The following is a description of a gene set: Human Gene Set: KEGG_MEDICUS_REFERENCE_MLK_JNK_SIGNALING_PATHWAY species: Homo sapiens Pathway Definition from KEGG: MLK -> MKK4/7 -> JNK MLK-JNK signaling pathway. Pathway ID: N01594. Pathway type: Reference. Pathway class: nt06526 MAPK signaling., and this is the list of marker genes: MAPK9, MAP3K10, MAP3K13, MAPK8, MAP2K7, MAPK10, MAP3K11, MAP2K4, MAP3K12, MAP3K21, MAP3K20, MAP3K9